The following is a description of a gene set: studied in species Homo sapiens Human Gene Set: MODULE_1 Ovary genes., and this is the list of marker genes: SELENOP, CPE, CDKN1C, FBXL7, PDLIM5, LPCAT1, MBNL1, RGS2, MYC, VEGFA, NID2, FMOD, SVIL, MAGI1, TMEM47, LHFPL2, AHDC1, COL6A2, NR4A1, TSC2, IL1R1, ULK1, GAS1, TRIP6, NAMPT, MFAP4, IFI16 (NCBI Gene Id 3428), PLAT (plasminogen activator, tissue type), SEPTIN10P1, RFTN1, ANGPTL2, TSPYL2, CFHR1, SOD3, FBN1, ADIPOR2, CCN5, SCP2, NFIL3, CCL15, RSRP1, MYL9, BIRC2, ITPR1, UBXN1, MAPRE2, FAT1, SNCG (synuclein gamma), COL3A1, SMARCA2, PTGIS, NCAM1, TNFRSF13B, TFRC, JUNB, SRRM2, GSTA4, SOX4, CDH11, GNG11, TRAM2, ITGA7, CD200, GABBR1, EFNA2, SLC2A3, STAT3, CDKN1A, LDOC1, CD34, PPP1R12B, TGM2, SDC1, AOX1, PDGFRB, TNXB, IGF1, CRIM1, RARRES2, CFD, ITGA6, DUSP6, TRO, DBP, COL15A1, ECM2, ITM2A, PTPN13, ALDH1A2, LTBP1, RBP1, SLPI (secretory leukocyte peptidase inhibitor), SFXN3, FUCA1, HSPB2, GPC3, TNFAIP3, AKAP17A (A-kinase anchoring protein 17A), ADAM19 (NCBI Gene Id 8728), TES, HSPG2, GJA1, LAMB2, ACTN1, KRT19, AMT, CITED2, EFS, ACKR1, MAOB (NCBI Gene Id 4129), NCALD (neurocalcin delta), RAB13, ADIRF, SRPX, IFNGR1, TPM1, EPS8, IL6, RRAD, CLEC3B, AOC3, MITF, SERPINH1, WDR7, CD14, LRP1, TIMP2, PDLIM3, PER1, SELE (NCBI Gene Id 6401), ROR2, LTBP2, CD302, ZYX, TNC, ENPP2, EMILIN1, GBE1, SGCE, FSTL3, IRS1, TFAP2B, ALDH7A1, ACTG2, COL1A1, MICAL2, TGFBR3, TCEAL4, MARF1, C1QB, SLC43A1, HEG1, PDPN, TBC1D2B, ENG, MXRA5, PDLIM7, FN1, IGFBP6, COL4A1, NDN, LUM, IGFBP3, LGMN, TGFBR2, GNG12, IGHM, CSRP1, CD44, IFI27, PLXND1, FHL2, RAB31 (NCBI Gene Id 11031), DEPP1, FOS, ALDH1A1 (aldehyde dehydrogenase 1 family member A1), PIM1, EMP2, CALD1, SGK1, PRSS23, SYNE1, TRIB2, PEG3, MYLK, HES1, BCL6 (NCBI Gene Id 604), DDX42, CD55, P4HA1, SLC6A2, TM4SF1, MFAP2, GADD45G, ANXA1, GET1, IGFBP2, PPP1R15A, DHRS3, TGFBI, APOE, AKR1C1, ACD, F13A1, PDZRN3, MAN2C1, CFH, DHRS2, WWTR1, LDLR, DLK1, IGFBP4, ITGB5, DBN1, PKD1, STAR, CXCL12, AUTS2, RGS5, FCGRT, IQGAP1, AQP1, TPM2, CPQ, CALU, GADD45A, CRYAB, FOSL2, CNN1, DST, SMTN, UGDH, PPP4R2, NR4A2, LMNA, THBS2 (thrombospondin 2), PSMC2, MYH11, SERPINE1, SFRP1, CHPF, GOLGA8A, DDX21, PDGFRL, BMERB1, SRGN, GATM, VAMP5, IRF9, QSOX1, IFIT1, JADE2, C1S, FBLN1, CRIP1, ID2B, FGFR1, EGR3, VWF, RNASE1, COL1A2, CD151, MAF, DAB2, NOTCH3, LOXL1, PLSCR1, PCOLCE, TNFRSF10B, PECAM1 (platelet and endothelial cell adhesion molecule 1), TSPAN7, EMP3, EGR1, PLEC (plectin), CCN1, SPON1, FXYD1 (FXYD domain containing ion transport regulator 1), CHGA, DPYSL3, GYG1, CTSK, MDK, G0S2, NFE2L2, RHOB, CCND1, COL6A1, PLA2G2A, TYRO3, THY1, AEBP1, CAV1, DUSP2, PTPRK, CCL3, MTUS1, GMPR, PEG10, GSTM1, CCND2, IER3, PTPN12 (NCBI Gene Id 5782), TSPAN3, S100A11, RASSF2, EMP1, LMO4, NR2F1, GPNMB, EDNRA, CCL2, GPX3, COL5A2, COL16A1, AR (NCBI Gene Id 367), ORM2, RABGAP1, ABLIM1, IGHG3, SMARCD3, LMOD1, SRSF5, EPHX1, SLC23A2, KCNMB1, RNASE4, C7, CDC42EP1, PNRC1, FILIP1L, JUN, ATF3, LAMB1, COX7A1, SEMA3C, AKAP12, NECTIN2, CAV2, PDGFRA, ZBTB20, CLEC2B, WFS1, COL6A3, NUPR1, FOSB, OPTN, DDR2, SEC11A, KLF4, CACNB3 (calcium voltage-gated channel auxiliary subunit beta 3), GFPT2, TIPARP, CHST15, BCAM, POU2F3, STAB1, RHOBTB3, MSX1, MAFF, MAN2B1, CNN3, FLNA, DENND2B (DENN domain containing 2B), KLF10, RBPMS, CAP2, GEM (NCBI Gene Id 2669), SLC39A6